Given this list of marker genes Il19, Anxa2, Apoc2l, Lipg, Trem2, Khsrp, Apoc2, Gpld1, Pcsk9, Ces1g, Lrpap1, Cnpy2, Abcc8, Gpihbp1, Apoc3, Nr1h4, Ldlr, Mylip, Ldlrap1, Crp, Hnrnpk, Csk (NCBI Gene Id 12988), Apoc1, here is a description of the gene set: studied in species Mus musculus Any process that modulates the rate, frequency, or extent of lipoprotein particle clearance. Lipoprotein particle clearance is the process in which a lipoprotein particle is removed from the blood via receptor-mediated endocytosis and its constituent parts degraded. Mouse Gene Set: GOBP_REGULATION_OF_LIPOPROTEIN_PARTICLE_CLEARANCE